The following is a description of a gene set: from publication Yevshin I, Sharipov R, Kolmykov S, Kondrakhin Y, Kolpakov F (PMID 30445619) Genes containing one or more binding sites for (Brwd1) in their promoter regions (TSS -1000,+100 bp) as identified by GTRD version 20.06 ChIP-seq harmonization. studied in species Mus musculus Mouse Gene Set: BRWD1_TARGET_GENES, and this is the list of marker genes: Arap1, Rchy1, Mrpl30, 1700031P21Rik, Ripor2, Lrrc8a, Tmem218, Mical1, Ergic3, Hsd11b1, Ctnna3, Slco2b1 (solute carrier organic anion transporter family, member 2b1), Atp11a, Etv4, Brwd1, Aida, Trappc2b, Or10j5, n-R5s13, Hsd17b13, Pwwp3a, Tmprss11a, Srsf4, Smpdl3b, Msh4, Mkks, n-R5s194, Ccdc148, Gm14248, 1700092C17Rik, Fbxl17, Ptbp2, Tmem87a, Rfc5 (replication factor C (activator 1) 5), Setd4, Gfra1, Knl1, Ganc, Rtl6, Necap2, Zfp706, Osbpl1a, 4933430I17Rik, 4930525G20Rik, Brca1, Rnf20, Igkj3, Pi4ka, Eef1d, Endou, Or4c125, Gm1647, Twf1, D330041H03Rik, Zfp426 (zinc finger protein 426), Lyzl4os, Vars1, Gm21985, Cdadc1, Gm10382, Trmt6, Haus2, Cd300c, Herpud1, Oma1, Gm17767, Nubpl, Tma16, Ap2s1, Ube2h, Igkj2, Ctnnal1, Maf1, Txndc12, Ppp1r15a, Cmip, Nup58, Nap1l4, Igkj1 (NCBI Gene Id 16074), Snord118, Arhgap29, Prkg1, Gata3, Polg2, Pi4k2a, Ncoa2, Chd8, Gm18604, Birc6, Smim7, Mir297b, Ier2, Sugt1, Gemin8, Rnf141 (NCBI Gene Id 67150), Commd5, Ranbp2, Gpn3, Cherp, 0610043K17Rik, Fcmr, Slx4ip, Fam210a, Gm22009, Igkc, Ehd4, Sharpin, Foxo3, Cep83, Mga, Rhoh, Slc45a4, Ptprc, Snx30 (NCBI Gene Id 329860), Oprd1, Slc12a6, A430035B10Rik, 1700037C18Rik, Nxt2, Dnmt3b, H2-T24, Twf2, Pde4d, Gm3665, Zbtb24, Hsd3b3, Apbb1ip, Dipk2b, Sucla2, Serpinf1, Ndufa2 (NADH:ubiquinone oxidoreductase subunit A2), Scgb2b25-ps, Pgbd5, Spag9, Fbxl18, G6pc1, Gna13, Ado, Gm12494, Usp5, Nuf2 (NUF2, NDC80 kinetochore complex component), Gm25939, Pgk1, Cdkal1, Pole3, Gm23607, Mir7068, Per1, Gm12855, Sac3d1, Ank3, Smok2a, Rps3a1, Mzt2, Slx4, Wbp2, Hnrnpl, Tm6sf1, Melk, Upf2, Ccr6, Ice1, Gm18432, Cblif, Albfm1, Foxp1, Gm13216, Elof1, Ankfy1, Cyp4f16, Gm11980, Eif2ak3, Gm11704 (NCBI Gene Id 108167872), Irak3, Lrrc57, Nek7, Ifna12, Gm9728, Hspbp1, Atg10, Cct3, 1700031F10Rik, Ccdc77, Gm6081, Fhip2a, Muc2, Ddx54, Rps6kb1, Araf, Ankrd9, Gatd1, Retnlg, Gm24207, 2510009E07Rik, Mrpl18 (NCBI Gene Id 98071), Ago3, Notch1, Rpp14, Gm6397, Evl, Btf3l4, Lyrm4, 4930557B06Rik, G6pdx (NCBI Gene Id 14381), Gm15564, Mageb16, Sp6, H3c3, Dpp7, Or52n20, Faap100, Gm15796, Cnot4, Gm22934, Emsy, Jak3, Kntc1, 5930411N13Rik, Gm15180, Suclg1, Tubd1, Kcna10, Glcci1, Hace1, Thap6, Gpam, Bcl2, Grcc10 (gene rich cluster, C10 gene), Prex2, Eaf2, Mir7020, Metap1d, Igkj4, Gm20557, Supv3l1, Ikbkg, Polr3e, Ppp6r3, Runx1, Fkbpl, Ehd1, Rps27-ps1 (NCBI Gene Id 100462728), Rita1 (NCBI Gene Id 97261), Tctn3, Srpra (signal recognition particle receptor alpha), Plekha4, Irak4, Gm13920, Laptm4a, Rnmt, Jaml, Gpr107, F8a, Nbr1, Hmgb1-ps5, Rnase4, Brox, H2bc3, Gm28513, Tmem71, Gm25345 (predicted gene, 25345), Gm5177, Gm15340, Zwilch, Marchf7, Phykpl (5-phosphohydroxy-L-lysine phospholyase), Zfp493, Ndufa13, Cul1, Diaph3, 0610039K10Rik, Pcdh1, Isoc2b, Anapc16, Syvn1, Atp5mk, Cyba, Mal2, Isca1, Tpp2, Rnu7, Zfp644, Tcp1, Samd4, Pdcd11, Nup153, Rpl18a-ps1, Foxred1 (FAD-dependent oxidoreductase domain containing 1), Atrn, Aff3, Arhgap21, Tnip2, Tigd5, Xrcc6, n-R5s88, Crbn, Igkj5, Gm10714, Wfdc9 (NCBI Gene Id 634940), Gm14002 (predicted gene 14002), I0C0044D17Rik, Pcdhga4, Trim29, Smc4, Tmod1, Mir6976, Wdfy4, Yjefn3, Ang, Pla2g2d, Slc35b4, Rabl6, Rnps1 (RNA binding protein with serine rich domain 1), Nudcd3, 1110019D14Rik, Bcl2a1c, Myl4, Meis1, Cluap1, Entpd1, Xpnpep2, Gpr19, Mir6236